Given this list of marker genes APOE, PANK2, ATG14, MIR548P, SIRT1, SORL1, PIK3CG, TMX1, LMF1, NR1H2, NR1H3, CNEP1R1, SLC27A1, DAGLB, PLIN5 (NCBI Gene Id 440503), MFSD2A, APOH, ABHD5, TBL1XR1, MIR29B1, MIR30C1, MBOAT7, DGAT2, APOC1, AADAC, SERPINA12, PNPLA2, APOA5, FBXW7, CIDEC, SIK1, KAT5, THRSP, APOA4, SREBF1, APOC2 (NCBI Gene Id 344), LDLR, CIDEB, APOC3, GNB3, APOBEC1, GPLD1, CTDNEP1, MIR192, SCARB1, C3, FUT1, here is a description of the gene set: studied in species Homo sapiens Any process that modulates the frequency, rate or extent of the chemical reactions and pathways involving triglyceride, any triester of glycerol. Human Gene Set: GOBP_REGULATION_OF_TRIGLYCERIDE_METABOLIC_PROCESS